The following is a description of a gene set: Abnormal persistent patency of the ductus arteriosus in postnatal life when birth was at 37 completed weeks of gestation or greater. Patent ductus arteriosus after birth at term species: Homo sapiens Human Gene Set: HP_PATENT_DUCTUS_ARTERIOSUS_AFTER_BIRTH_AT_TERM, and this is the list of marker genes: ATP6V1E1, SON (NCBI Gene Id 84155), BPTF, CALM3, FOXP2, PSMD12 (proteasome 26S subunit, non-ATPase 12)